Given this list of marker genes ACADVL (acyl-CoA dehydrogenase very long chain), PGD, HAL (NCBI Gene Id 3034), UQCRQ, MGST1, PPP2R5D, ETFB, PLK1, FAH, CPQ, MCCC2, FLOT1, MAP7, MTHFS, CYB5A, PLGLB2, CDK1, MPPED1, GAD2, TM7SF3 (transmembrane 7 superfamily member 3), CIAO2A, ACADSB, COMT, PYGL, CTSL, PRDX6, PCYOX1, MAP2K5, SDS, ARMT1, SPTSSA, GSTM2, HAGH, APOC2, FTL, GGT1, XPNPEP2, PIN1, IRAK1, MTUS1, NAT2, GGH, PCNA, CYP4A11, SULT1E1, A2M, HYAL1, NEDD4, NNMT, XPC, ALDH9A1, NAT1, FMO4, ENPP1, PEG10, CHI3L1, CYP1A1, ALDH4A1, GLYAT, AGXT, DECR1 (2,4-dienoyl-CoA reductase 1), PFKFB3, NHERF1, PCBD1, MGLL, CTSC, LCAT, GSTM4, SDHC, CPB2, GSTA2, CDK5, TNS1, ACO1, CD320, NEDD8 (NEDD8 ubiquitin like modifier), AGL, CYP3A4, CYP3A7, CTSS, HACL1, GLB1, P4HB, SORD, MAP2K6, PDK4, DHRS4, GOT2, ALDH1A1, FKBP5, PCK2, DUSP6, IMPDH2, CADM1, NQO2, RAD54L, MANF, ABCC1, GPT, SNAI2, PYGM, UGDH, DAPK1, MCFD2, VNN1, CNOT6, SRD5A2, ALAS1 (5'-aminolevulinate synthase 1), NME2, F2, EBP, FH (NCBI Gene Id 83748), BLVRB (biliverdin reductase B), ALPI, TDO2, BNIP3, MTSS1, H2BC21, PTPN7 (NCBI Gene Id 5778), LYZ, IMMP2L, HPD, CEMIP2, DUSP3, PNRC1, GPX3, LMO3, COX7B, RPLP1, UQCRC2, HSD11B1, ACSL1, OAT, OAS1, CYP26A1, PRDX4, UGT2B15, MXI1, NDUFAF1, F12, DDX42, SRP9, GALT, PLA2G2A, BBOX1, UBE2L6, PHB2, TREH, PLPP1, GLUD1, DHRS7, PDK2, TALDO1, LACTB, FUCA1 (NCBI Gene Id 2517), PDIA4, CELA3A, SEPTIN2, TMT1A, SUMO1, RAB20, GCH1, TMED10, CBS, HADHA, AADAC, GSTA3, UGT2B7, GATM, MMP9, NUPR1, HEXB, CBR1, ADAM9, DDT, GOT1, CYP2C8, RHOBTB3, IDH1, GLO1, NRG1, PRSS2, C1R (complement C1r), HSD17B4, MST1, UGP2, SULT1A3, ALDH7A1, ST6GAL1, GPRASP2, HDAC2, CA2, BHMT, INSIG1, MPP1, HERPUD1, ABCD3, RPLP2, BTD, ARG1, ID2B (NCBI Gene Id 84099), ALDOA, CDK4, ATP5F1E, C19orf12, ECHS1, SORBS2, GPX1, MRPL40, TRDMT1, TBXAS1, RND3, CYP2J2, UPP1, PEBP1, C2, GYS2, ENPEP (glutamyl aminopeptidase), SV2B, SOAT1, PAH, MAGT1, CYP27A1 (NCBI Gene Id 1593), EHHADH, CPN1, IGF2BP3, MELK, MDH1, PIGP, PLCG2, NCOA4, GPX2, MTHFD1, RRM2, DUSP5, PRDX1, FMO3, SOD1, ZNF248, CHPT1, PIM1, SAT1, SCD, HPGD, SLC25A15, CAMK1, MYO1E, KLHDC2, PCYT2, CA5A, PRSS8, MMP2, MSMO1, LIPA, BCHE, IFITM3, NQO1, RAB5C, CSNK2A1, PNP, CYP2B6, DNASE1L3, GART, DDX3Y, ARL4D, FES, TMBIM6, CYP11B2, SELENBP1, DIO1, GALE, CES1, SERPINB2, ACSL3, TOP2A, VAV3, PDIA3, LILRB3, FKBP8, MFSD1, KYNU, AKR1C3, HSPA8, PEPD, SPG21, MGST2, ATP5F1B, SERPINE1, PLG, SUCLG1, PON1, CDKN3, FADS2, SAR1B, PSMA2, AKR1C1, ADK, XDH, ACOX2, TUBGCP6, KIF23, MMP7, ARSA, TMEM230, FURIN, QDPR (quinoid dihydropteridine reductase), HINT1, DAO, LAP3, BCKDHB, LAPTM4A, ABCC3, DPYSL3, RNASE4, STRADB, HPN, DDC, CETP, GOLPH3, GGTLC1, EPHX2, LDHA, ACADM, BAAT, TTK, PTS, ADH4, ISG20, RPS27, here is a description of the gene set: Catalytic activities / metabolism. Human Gene Set: MODULE_212 species: Homo sapiens